Given this list of marker genes Cartpt, Spx, Gdf15, Nenf, Bbs2, Bbs4, Nucb2, Npff, Fbn1, Gfral, Nod2, Pomc, Cck, Ghrl, Gcg, Sct, Or4m1, Lep, Oprm1, Sctr (NCBI Gene Id 319229), Htr4, Npy, Ghsr (NCBI Gene Id 208188), Galp, Pter, Mkks, Ucn, Slc22a3, Htr2c, Ppara, here is a description of the gene set: Mouse Gene Set: GOBP_REGULATION_OF_APPETITE studied in species Mus musculus Any process which modulates appetite, the desire or physical craving for food.